The following is a description of a gene set: Cytokine-activated STAT proteins dimerize and bind to high-affinity motifs, and N-terminal domain-mediated oligomerization of dimers allows tetramer formation and binding to low-affinity tandem motifs, but the functions of dimers versus tetramers are unknown. We generated Stat5a and Stat5b double knock-in (DKI) N-domain mutant mice that form dimers but not tetramers, identified cytokine-regulated genes whose expression required STAT5 tetramers, and defined consensus motifs for dimers versus tetramers. Whereas Stat5- deficient mice exhibited perinatal lethality, DKI mice were viable, indicating that STAT5 dimers were sufficient for survival. Nevertheless, STAT5 DKI mice had fewer CD4+CD25+ T cells, NK cells, and CD8+ T cells, with impaired cytokine-induced proliferation and homeostatic proliferation of CD8+ T cells. DKI CD8+ T cell proliferation following viral infection was diminished and DKI Treg cells did not efficiently control colitis. Thus, tetramerization of STAT5 is dispensable for survival but is critical for cytokine responses and normal immune function. Genes up-regulated in STAT5 double knock-in T cells: control versus IL2 stimulation for 6h. studied in species Homo sapiens from publication Lin JX, Li P, Liu D, Jin HT, He J, Ata Ur Rasheed M, Rochman Y, Wang L, Cui K, Liu C, Kelsall BL, Ahmed R, Leonard WJ (PMID 22520852) Human Gene Set: GSE36888_UNTREATED_VS_IL2_TREATED_STAT5_AB_KNOCKIN_TCELL_6H_UP, and this is the list of marker genes: CHCHD7, SEPTIN6, TRNAU1AP, PTPRF, SH3PXD2B, IFT27, CRACD, FPR2, VEGFA, PREX1, FCGR2C, SHOC2, GLDC, WDR17, MBOAT2, CD209, MAGEA1, LILRB3, JAM2, PRKD3, CD14, SEPTIN10, CD47, RPGR, TRAF3IP2, THBS1, WDR64, ELL, CLIC1, INSIG2, IL6ST (NCBI Gene Id 3572), SYT17, CPD, LINC02209, SLC16A10, RYBP (RING1 and YY1 binding protein), NAMPT, SEMA4C, LHFPL1, CYRIA, CEP135, GSTA4, ARMT1, HS3ST3B1 (NCBI Gene Id 9953), SAMSN1, SOCS3, BTBD10, FCRLB, CRLF3, ANO10, ZBTB1, GNG2, LILRA6, C3orf70, BST1, CDC42EP5, LIMK2, SOCS1, MIR3142HG, STXBP5-AS1, ARHGAP19, SLC4A8, SPTLC2, NAGS, FIGNL1, PLSCR1, HTR7, C1orf115, SOS1, S100A8, PRKCD, SPACA6, NEUROD1, PTGES, ANKRD13D, MS4A7, TET2, LYN, PFKFB3, LILRB1 (leukocyte immunoglobulin like receptor B1), PCGF3, FPR1, GPR83, MB21D2, MED30, AATBC, PIK3AP1, VDR, GUSBP3, SLC41A2, SOD2, ISX, CA13, LRRC4 (leucine rich repeat containing 4), APH1B, OLIG2, LRATD1, C2CD3, CYP3A5, CAB39, AFDN, MAP3K5, HYCC1, AKAP9, TMEM115, CISH, LRRC25, S100A9, P2RY6, TRIM13 (tripartite motif containing 13), TNFRSF1B (NCBI Gene Id 7133), TRIP10, IER5, LILRA1, USP32, ANXA2R-OT1, ATP13A3-DT, ZC3H12A, SOCS2, CCM2L, MYO1G, SLC7A7, S100A12, CORO1A, PLAC8, ULK2 (NCBI Gene Id 9706), KSR1, VNN2, RAB31, PMP22, RARA, HRH1, IQUB, TMEM168, MIGA2, CLEC4G (NCBI Gene Id 339390), SESN2, MAF, SAMD4B, RAB27A, PLK2, HAS1 (NCBI Gene Id 3036), ETV3, P2RY2, SUSD1 (NCBI Gene Id 64420), BEST1, MEGF9, GRB2, NFE2L1, GLCE, TGFA, NFKBIZ, VNN3P, LINC01465, MXD1, IL1B, SASH1, FCGR2B, CASP5, ASCL1, SMPDL3A, HCK, EDEM2, IFT43, ESRRG, N4BP1, FSD1L, NOD2, NEFH, VAV1, MAP3K4, TNIP3, IL6-AS1, ATP7B, ASPHD2, CCL19, MIR4453HG, GK5, ITGB8, SLC2A10, TM9SF4, FCGR2A, USP3, LAT2, IER3, SERPINB9, DDIT4, ADGRE3, LILRA5, TBC1D30, PLAGL2, STEAP1B, EMILIN2, DMRT1